Given this list of marker genes ZP4, PAEP, ZP3, OVGP1, ASTL, here is a description of the gene set: studied in species Homo sapiens Human Gene Set: GOBP_REGULATION_OF_BINDING_OF_SPERM_TO_ZONA_PELLUCIDA Any process that modulates the frequency, rate or extent of binding of sperm to the zona pellucida.